Given this list of marker genes Sesn3, Rptor, Mtor, Tti1 (NCBI Gene Id 98972), Larp1, Mapkap1, Prr5, Sesn2, Prr5l, Rictor, Mlst8 (MTOR associated protein, LST8 homolog (S. cerevisiae)), Akt1s1, here is a description of the gene set: studied in species Mus musculus Mouse Gene Set: GOCC_TOR_COMPLEX A protein complex that contains at least TOR (target of rapamycin) in complex with other signaling components. Mediates the phosphorylation and activation of downstream signaling components including PKB (AKT) or S6K.